Given this list of marker genes YDJC, DHX36, ATP11B (NCBI Gene Id 348830), PKM, IDH3G, RPS6KA2, PGM2, ENDOG, GCLC, STK4 (NCBI Gene Id 6789), OPA1, NEK6, PLSCR3, MAST2, FAN1, ERN1, CDC42BPA, RPS6KA6, IDI1, MAP3K7, GNAI1, PLK1, ADPRS, ATP8B1, TSSK4, ERN2, NIM1K, MTG2, NUDT5, WRN, ENO3, STK11, FEN1, TDG (thymine DNA glycosylase), ATP8B2, MARK2, MTHFD2, IDH1, DUT, ABL2, MOV10L1, TREX2, HMGCL, PRPS1, MSH6, PCK1, XXYLT1, MAP3K20, PGM1, AASDHPPT, SNCA, SRPK2, DXO (NCBI Gene Id 1797), RP2, MSH2, DIS3L2, NUDT3, PPA2, POLR2A, ADPRH, ENOSF1, ATP8A1, PKLR, ILK, PPM1A, PIF1, SIK1 (NCBI Gene Id 54018), DCTPP1, MTPAP, PPM1B, NLK, ENO2, POLR1A, SEPTIN4, SUCLG2, TREX1, MARK1, OXSR1, TSSK3, MAST4, HPRT1, NT5C1B, PRTFDC1, ATP10A, ATP9A, ME1, CERK, ENO1, CILK1 (ciliogenesis associated kinase 1), FIGNL1, PRPSAP1, ATP8A2, UBA2, STK38L, LATS1, NME1, TSSK1B, ADCY10, CIB2, CDC42BPG, ATP4A, RPS6KA5, ARF1, ARL3, PLSCR1, NLRC4, MAPK12, PI4K2A, HACL1, BRSK2, TESC, TSSK6, IRAK3, EYA2, WEE1, BRSK1, S100P, ATP10D, EXD2, THG1L, IMPA1, LRRK2, ADCY2 (adenylate cyclase 2), HPGDS, GEM, ENOPH1, SRPK1, DYRK3, ILVBL, WEE2, NT5C1A, MAP2K7, PRIM1, PDXK, PGM5, MAST3, SRR, GEN1 (NCBI Gene Id 348654), PGM3, EPHX2, SIK3, NUDT19, IDH3B, STK38, TSSK2, NUDT7, EXTL3, STK26, ALPI, ATP11C, RPS6KA3, GTPBP10 (NCBI Gene Id 85865), RPS6KA1, NUAK2, ADSS1, ITPK1, PSPH, POLR3A, RHEB, FOXK2, ATP8B3, SPHK1, PRPSAP2, PDXP, SIK2, ATP8B4, FARSA, GSS, SUCLA2, ATP9B, MAP3K6, RAN, TKT, ITGB1, PGP, PRPS2, ADSS2, CIB3, NUDT16, LIG4, PRKACB, STK3, TDP2, NT5C3A, CDC123, XYLT2, CIB4, MAST1, THTPA, ADPRHL1, MORC2, ABL1, NT5C3B, PDCD6, TUFM (NCBI Gene Id 7284), MVK, NUDT12, CIB1, ENO4 (enolase 4), RAP2A, IRAK4, PDE2A, PINK1, COMT (NCBI Gene Id 1312), MAP3K8, SNRK, CDC42BPB, MAP3K5, IDH2, ATP10B, ALPP, PPA1, NUDT8, PPM1N, PRPS1L1, CLYBL, ATP11A, IDH3A, CDK2, DYRK2, ENDOV, RRAGC, PRKACA, POLQ, PAPOLA, FARSB, REXO2, RNASEH1, TPPP, RPS6KA4, TOP2A, here is a description of the gene set: Binding to a magnesium (Mg) ion. Human Gene Set: GOMF_MAGNESIUM_ION_BINDING species: Homo sapiens